Given this list of marker genes MGP, EFNA3, SYK, FBXL19, ANKRD53, PTPRQ, PPP2R2D, HYOU1, GFAP, SESN3, VAX1, SETX, CX3CL1, UNC79, FN3K, PHYHIP, COL10A1, LDB1, CPLX2, ANP32A, FAM193A, SERPINA1, PRDM16, TADA1, KSR2 (kinase suppressor of ras 2), DLX3, ANXA5, NBL1, DMAC2, VSTM2L, IGLON5, TMEM132E, BCAM, STK40, AP1M2, NEDD9, WASF1, SETD1A, ATP6AP2, PCYT1B, SEMA6C, HOOK3, TCEANC2, GCSAML, PAX5, here is a description of the gene set: Genes predicted to be targets of miRBase v22 microRNA hsa-miR-6798-5p in miRDB v6.0 with MirTarget v4 prediction scores > 80 (high confidence targets). Human Gene Set: MIR6798_5P from publication Chen Y, Wang X (PMID 31504780) species: Homo sapiens